The following is a description of a gene set: Genes containing one or more binding sites for (Smad6) in their promoter regions (TSS -1000,+100 bp) as identified by GTRD version 20.06 ChIP-seq harmonization. from publication Yevshin I, Sharipov R, Kolmykov S, Kondrakhin Y, Kolpakov F (PMID 30445619) studied in species Mus musculus Mouse Gene Set: SMAD6_TARGET_GENES, and this is the list of marker genes: Traf2, Lad1, Rnf166, Eeig1, Rrp1, Alyref2, Zbtb7b, Cblc, Ovol2, Tle6 (transducin-like enhancer of split 6), Rnu7, Pgm2, Mageb16, Poldip3, Il17re, Tinf2, Tmem54, Rbbp8nl, Ubl5, Epcam, Gramd2b, 1700008J07Rik, Srcap, Cds1 (NCBI Gene Id 74596), Jup, Brme1, Ctu2, Hlf, Tap1, mt-Tp, Cdca5, Arrdc1, Btbd9, Fbxl12, Rnf103, Slc44a2, Vps37b, Mpi, Sik1, Josd1, Psma5, 2610005L07Rik, Myo10, 3110031N09Rik, 1700010K24Rik (RIKEN cDNA 1700010K24 gene), Prom2, Rbbp8, Nlrx1 (NCBI Gene Id 270151), Mir6236, Arhgef10l, Grcc10, Slc7a9, Rnu11, Gm16136, Rnf225 (NCBI Gene Id 97353), Gm13049, Zfp882, Coq10b, Fbxl19, Grb7, Cyp39a1, Ap5b1, Syt8, Rnu12, Gm34086, C920006O11Rik, Nr2f6, Gga1, Ccnt1, Gm15564, Gm25939, Palm3, Hps4, Chmp4b, Srrd, Slc25a27, Zswim1, Gm24641, Faf1, Duxf1, Hivep2, Rlf, Gm11240, Med16, Mir203, Zfpl1, Fem1al (fem-1 homolog A like), Rasef, Guf1